Given this list of marker genes Tnc, Wnt2b, Shh, Wnt5a, Met (met proto-oncogene), Hoxa5, Hgf, Fgf10, Foxa1, Mir875, Fgf7, Fgfr1, here is a description of the gene set: Mouse Gene Set: GOBP_MESENCHYMAL_EPITHELIAL_CELL_SIGNALING Any process that mediates the transfer of information from a mesenchymal cell to an epithelial cell where it is received and interpreted. species: Mus musculus